Given this list of marker genes DUSP21, PTPN1, ACP4, PTPN11, PTPN9, DUSP7, PTPN2, PTPRZ1, EPM2A, PTPRF, PTPN12, PTPN13, TNS2, DUSP18, DUSP5, DUSP3, DUSP6, PTPRS, PTPRT (NCBI Gene Id 11122), DUSP1, PTPN6, PTPRJ, here is a description of the gene set: The removal of phosphoric residues from peptidyl-O-phospho-tyrosine to form peptidyl-tyrosine. species: Homo sapiens Human Gene Set: GOBP_PEPTIDYL_TYROSINE_DEPHOSPHORYLATION